Given this list of marker genes TICAM1, TLR3, here is a description of the gene set: Reactome Pathway: TICAM1 deficiency - HSE Inborn errors of interferon immunity due to defects in toll like receptor 3 (TLR3)-mediated signaling underlie pathogenesis of herpes simplex virus type 1 (HSV1) encephalitis (HSE) in some children (Netea MG et al. 2012). Autosomal dominant (AD) and recessive (AR) deficiencies of (TIR) domain-containing adaptor inducing IFN-beta (TRIF or TICAM1) are also associated with impaired IFN production and predisposition to HSE in the course of primary infection by HSV1 (Sancho-Shimizu V et al. 2011). species: Homo sapiens part of: Diseases associated with the TLR signaling cascade